The following is a description of a gene set: Association of TriC/CCT with target proteins during biosynthesis species: Homo sapiens Human Gene Set: REACTOME_ASSOCIATION_OF_TRIC_CCT_WITH_TARGET_PROTEINS_DURING_BIOSYNTHESIS, and this is the list of marker genes: CCT4, KIF13A, KIFC3, FBXW5 (NCBI Gene Id 54461), SPHK1, LONP2, FBXW2, GBA1, CCNE1, FBXW9, HDAC3, CCT8, WRAP53, SKIC2, USP11, CCNE2, CCT6A, GAPDHS, FKBP9, FBXW7, NOP56, FBXO4 (NCBI Gene Id 55087), CCT3, FBXO6, DCAF7, XRN2, CCT2, ARFGEF2, CCT7, TCP1, FBXL5, CCT6B, TP53, AP3M1, STAT3, CCT5, FBXL3, FBXW10, FBXW4